The following is a description of a gene set: Genes containing one or more binding sites for (Hoxa11) in their promoter regions (TSS -1000,+100 bp) as identified by GTRD version 20.06 ChIP-seq harmonization. Mouse Gene Set: HOXA11_TARGET_GENES from publication Yevshin I, Sharipov R, Kolmykov S, Kondrakhin Y, Kolpakov F (PMID 30445619) studied in species Mus musculus, and this is the list of marker genes: Dhx34 (DExH-box helicase 34), Ubr4, D030047H15Rik, 4933405D12Rik, Pkia, Sdf4, Cct5, 2610300A13Rik, Zc3h8, Mis18a, Palb2, Mrpl32, Hoxc6, Xpo5, Tex14, Gmcl1, Yipf2 (NCBI Gene Id 74766), Stra6l, Gm9826, Gabrb1, Poc1b, Hoxd9, Srsf7, B3galt6, Ttc39d, Gm34727, Abhd13, Zfp64, Uqcrc1, Ranbp3, Nup50, Mri1, Sugp2, Capn6, Armc6, Polr2i, Mrpl9, Gpr19, Mir6969, Opa1, Polr2a, Fam227a, Gm13652, Rian, Rapgef6, Zfp236, Atp5mg, Trim23, Atpsckmt (NCBI Gene Id 68073), Naa12, Leng8, Cby1, Mir615, Vapb, Zfp300, Rfxank, Mettl22, Cog6, Grip1os2, B230219D22Rik, Txnl4a, Tbcb, Mea1, 2600014E21Rik, Polh (NCBI Gene Id 80905), Ndrg3, Gm38562, Lig4, Trappc13, Actr3, Rsl24d1, Rab3gap2, Psma2, Atad2, Tmem109, Borcs8, Ncan, Dctn5, Klhdc3, Snrnp70, Ints2, Ssbp3, Ftl1, Rab14